Given this list of marker genes Trps1, Atp2b2 (ATPase, Ca++ transporting, plasma membrane 2), Trip12, Apol10b, Gm4894, Arid5b, Rbm12, Lrp6, Naa30, Kcnb2, Wnt5a, Rac2, Csnk2a2, Cts8, Naa12, Rora, Aard, Cnbp, Tpbg, Ift140, Abhd13, Ptpn2, Hps3, Bloc1s3, Mier1, Yes1, Naa16, Mageb3, Tmx4, Plek, Celf2, Prom2, Map4, Mtrr, Dtwd2, Tbl1xr1, Myt1l, Tbx3, Shisal2b, Cd55 (NCBI Gene Id 13136), Dusp6, Mllt1, Mex3a, Cox15, Snx12, Vwc2l, Grk3, Copb1, Plcb3, Ttc12, Ssh2, Tcstv2b, Champ1, Map3k4, Mrgprb2, Mast4, Tfam (transcription factor A, mitochondrial), Snrpb, Cd200r4, Fndc3a, Foxo1, Mark2 (MAP/microtubule affinity regulating kinase 2), Zfp26, St8sia4, Ifnlr1, Eml4, Zmat1, Xiap, Speer4d (spermatogenesis associated glutamate (E)-rich protein 4D), Zfp955a, B4galt7, Cds1, Cflar, Rnf4, U2surp, Ccdc34, Synpr (NCBI Gene Id 72003), Rb1cc1, Dicer1, Prelid3b, Fam53c, Cdk7, Stxbp5, Ythdc1, Fbxl14, Cxcr4, Asah1, Sfxn3, Gab3, Unc5c, Snapc1, Adrb2 (adrenergic receptor, beta 2), Utp4, Fat1, Adra1a, Zmym5, Cnot6, Ttc6, Nop16, Ap1g1, Arid1b, Nucks1, Tmtc1, Zhx3 (zinc fingers and homeoboxes 3), Ado, Ranbp6, Map3k2, Nfya, Zfhx4, Washc4, Hccs, Impa1, Azi2, Slc8b1, Dynlt3, Etv1, Gpr158, Gm21190, Pabpc5, Speer4c1, Hook3, Samd8, Piezo2, Sirt6, Tulp4, Bicd1, Lrrc58, Metrn, Lgmn, Mindy2, Satb2, Acer3, Rsbn1l, Slc35a5, Pbx2, Selenoi (selenoprotein I), Pou2f1, Tirap, Notch1, Fthl17e, Mphosph9 (M-phase phosphoprotein 9), Poldip3, Kras, Tmem170, Mboat7, Zbtb41, Lrrc38, Camk2a, Ythdf3, Tmem263, Paip1, Gm10377, Znrf2, Mia3 (NCBI Gene Id 98575), Ptprf, Entpd4, Larp4 (NCBI Gene Id 52147), Zfp345, Nlgn2, Zbtb44, Cdk17, Ppih, Aplp2, Zfp280c, Bend6, Neurod6, Csnk1a1, Cpeb4, Hsp90aa1, Fam3c, Mrpl35, Pafah1b1, Htr1a, Jade1, Tnrc6b, Uri1, Cbfb, Sall1, Dcaf17, Ssx2ip, Zbtb21, Edem3, Septin8, Ppp4r3b, Nrxn3, Tet1, Ipcef1, Casp3, Armc2, Kcnh5, Pak3, Col19a1, Tm9sf3, Nbeal1, Fam227a, Tfap4, Fzd6, Entpd7, Akap6, Gse1, Sgk1, Tbx18, Homer2, Prkd3, Sgcz, Dcun1d3, Ccdc93, Tube1, Dstyk, Hyal4, Tmppe, Ddx3x (DEAD box helicase 3, X-linked), Prrg4, Cep170, Stxbp6 (NCBI Gene Id 97823), Hipk1, Dpp8, Sntb2, Arl8a, Erich5, Fbxw7, Reep1, Ppp6c, Eif2s3x, Aff2, Boc, Tcstv2c, Pou3f2, Sgcb, Syt14, Frmd4a, Syt6, Gja8, Cdh2, Rnf170, Zbtb37 (zinc finger and BTB domain containing 37), Ift80, Prickle2, Hsf5, Stk10, Fbxo28, Dmrt1, Rab18, Hepacam2, Tgif1, Scn8a, Eif2b1, Rmnd5a, Espnl, Fgf9 (fibroblast growth factor 9), N4bp2l2, Fgf10, Naaladl2, Marveld1, Dars1, Gria3, Elavl1, Bcl6b, Ldlrad3, Maoa, Tyms, G2e3, Matn1, Ntng1, Gpm6a, Asb8, Ppfibp1, Vezf1, D1Pas1, Mgat2 (mannoside acetylglucosaminyltransferase 2), Lonrf3, Fcgr4, Rhobtb1, Foxp2, Terf1, Scd4, Luzp2, Rab23, Cd44, Iws1, Nap1l1, Trim6, Klhl15, Gfra2, Hmgb2, Ralbp1, Creb1 (cAMP responsive element binding protein 1), Arrdc3, Vps13d, Twf1, Ptpra, Rnf44, Ptk7, Arl13b, Uqcc4, Tcstv2a, Gpr22, Smc6, Zfp518a (zinc finger protein 518A), Fstl1, Tbc1d30, Fgfr1, Zbtb34, Adra2b, Asb7, Gm20815, Gsk3b, Agl, Osbpl6, Vsig10l, Med18, Sox5 (SRY (sex determining region Y)-box 5), Plaur, Cutal, Tenm2, Ercc6, Ranbp3l, Slc10a2, Cdc42ep4, Nr6a1, Wasl, Esrrg, Lrrtm3, Zfp799, Fthl17a, Hoxd11, Pou4f1, Samd4, Ran, Pex13, Chml, Mdga2, Kdm1a, Rai2, Gngt1, Anapc1, Megf10, Phf14, Dnajc6, Exoc5, Cpeb2, Tcstv3, Osbpl8, Ctnna3, Crebzf, Tmem88b, Ct55, Nufip2, Slc15a1, Ints12, Rbpj, Hycc2, Tceanc, Psme3, Nab2, Snurf, Rest, Syt15, Cyria, Itsn1, S1pr3, Kmt2a, Zfp462, Fut11, Oprm1, Rplp0, Satb1, Ckap4, Trim21, Pde8b, Bend4, Slc22a23, Sgms2, Celf1, Dmp1, 1700001F09Rik, Mvb12b, Fsd1l, Zfx (zinc finger protein X-linked), Fubp1, Tanc2, Maml3, Senp5 (SUMO/sentrin specific peptidase 5), Zfp512, Mllt11, Rpusd2, Rflnb, Cacna1d, Scai, Rictor, Mef2c, Cxcl12, Il1rap, Rbm20, Fbxo3, Prickle1, Gm8267, Kdm5a (NCBI Gene Id 94042), Ecm2, Paqr6, Cln8, Bloc1s2, Glis3, Mbnl2, Thsd7a, Usf3, Pou3f1, Hapln1, Tcstv4, Elmod2, Slc10a4-ps, Scn3a, Zfp113, Nhlh2, Cadps2, Dock6, Acsf2, Tdrd3, Ankrd13c, Wwtr1, Tent5a, Far1 (NCBI Gene Id 72904), Dtx3l, Trim33, Sycp3, Shisa9, Bri3bp, Nmt2, Il17re, Phf8, Slc16a1, Tcstv7a, Irf1, Poglut3, Nat14, Six4, Ddhd1, Lclat1, Ctnnd1, Dag1, Nfib, Zfp292, Zfp719, Tgfbr3, Gabrb2, Esyt2, Tmed9, Slc10a4, Canx, Bcl2l12, Ppp1r27, Tmem87b, Hykk, Spryd7, Ccdc92 (NCBI Gene Id 52823, coiled-coil domain containing 92), Adam17, Onecut3, Galc, E4f1, Hs3st5, Bdnf, Mbtd1, Ssr3, Dgkb, Msantd3, Slf2, Epb41l2, Gm5127, Zfand4, Slc7a2, Nectin3, Sash1, Pef1, P2ry4, Scn7a (sodium channel, voltage-gated, type VII, alpha), Bclaf1, Itgav, Tsc22d3, Scfd1, Zmat3, Lrba, Fkbp5 (NCBI Gene Id 52022), Depdc1b, Scg2, Lnpep, Neu3, Mtcl2, Ifnar2, Khdrbs2, Hmgcll1, Ep300, Rpgrip1l, Tcf7, Cebpg, Ctsc, Kalrn, Srgap1, Ppm1k, Gtf2a1, Ddhd2, Prtg, Usp32, Aebp2, Hbegf, Zfp654, Elovl7, Unc13c, R3hdm2, Gtf3c3, Zfp422, Prkaa2, Tcf4, Sppl2a, Sema3c, Pde4c, Fosl2 (fos-like antigen 2), Apbb2, Dusp1, Faf1, Tnpo1, Atrn, Synpo2, Hoxd9, Gpr107, Nras, Pcdhb16, Trim35, Arl5a, Mtf2, Dennd6a, Tsen34, Tcerg1, Ccdc126, Vamp4, Atp6v1a, Pten (NCBI Gene Id 70161), Igf1, Akap5, Phlpp1, Gna13, Ptpn21, Gm5796, Ttll7 (tubulin tyrosine ligase-like family, member 7), Alg6, Plch1, Zfp84, Ereg, Gpat3, Ranbp1, Kcnk3, Runx1t1, Bcat1, Semp2l1 (SUMO/sentrin specific peptidase 2-like 1), Tcp10c, Elp2, Arih1 (NCBI Gene Id 23806), Dusp10, Gbx2, Kif1c (NCBI Gene Id 237826), Adamts5, Lrrtm4, Szrd1, Lhx2, Nfe2l1, Ccnd2, Clcn5, Prkx, Plekhm3, Pcyox1l, Ap3m1, Bcl11a, Pkp4, Zfhx3, Shisa2, 4921517D22Rik, Actr6, Tgfb2 (NCBI Gene Id 98738), Dach1, Timd2, Thumpd1, Septin11, Ppp1cb, Wdr25, Cbln4, Gna14, Gdpgp1, Lrrn4cl, Enah, Sgpp1, Clock, Kdm4a, Cpeb3, Psg16, Myocd, Ube4a, Irf2bp2, Pcdhb22, Il19, Vkorc1l1, Kif5c, Tfdp1, Abca8a, Cxxc4, Fut9, Dap3, Rab6b, Nup107, Ehf, Arhgap19, Otud7b, Trio, Sec63, Dgke, Get1, Myo1b, Mllt3, Paqr9, Pcdh18, Prdm1, Cnnm3 (cyclin M3), Marf1, Kpna2, Elavl4, Zfp329, Cdc14a, Smc5, Lsm6, Apod, Cbx5, Zc3hav1l, Cyp26b1, Itpripl2, Ooep, Ptf1a, Cdh1 (NCBI Gene Id 12550), Extl1, Mylk4, Herpud2, Skint7, Pank3, Mapk8, P2ry1, Myod1, Vav2, Zfand1, E130308A19Rik, Setx, Prb1b, St3gal4, Braf, Psd3, Ctso, Preb (NCBI Gene Id 97258), Tmed10, Thbs2, Eif5a2, Pcdhb19, Gm10375, Sh3bgrl2 (SH3 domain binding glutamic acid-rich protein like 2, NCBI Gene Id 68100), Yipf6, Smim13, Kbtbd7, Cep15, Cdc37, Prpf18, Trim30a, Slc25a51, Grm5, Parpbp, Ebf2, Cops7b, Arfgef1, Socs4, Crebrf, Ywhab (NCBI Gene Id 80438), Trmt9b, Fbxo43, Afap1, Kctd12, Zrsr2, Plaa, Prr7, Parp11, Ubtd2, Zfp92, Ugcg, Riok3 (RIO kinase 3), Pdcd10, Rarb, Elf2, Macf1, Nfat5, Atl2, Ythdc2, Hnf4g, Rere, Ddx39b, Gm5148, Supt16, Fign, Deptor, Cdh20, Arl5b, Med12, Calml3 (NCBI Gene Id 70405), Cdk6, Luc7l, Tcstv5a, Slc35f1, Dennd2c, Cstf3, Fli1, Sgce, Tspan31, Sin3b, Htr4, Pbrm1, Sdr16c5, Shroom2, Nip7, Noc2l, Faxc, Serpinb10, Gpr12, Runx3, Orai2 (NCBI Gene Id 677007), Tasor, Pcdh9, Fpgt, D16Ertd472e, Ctnnd2 (catenin delta 2), Zfp106, Gmip, Bnip5 (NCBI Gene Id 78191), Rrp1b, Igfbp5, Bdp1, Glipr2, Traf3ip1, Pogk, Arb2a, Cyp2u1, Ccnjl, Hspa5, Slc25a46, Jun (jun proto-oncogene), Actc1 (NCBI Gene Id 11464), Arhgap28, Upf1, Wdtc1, Cand1, Dnmt3a, Zbtb7a, Polr3b, Snx11, Tmub2, Zdhhc21, Mafb, Ddx46, Rimbp2, Rabgap1, Trim32, Mapk10, Syn2, Speer4e1, Fbn2, Cmtm6, Atxn7, Zbtb26, Cacna1c, Rorb, Gm21083, Semp2l2a, Jarid2, Sec22b, Onecut2, Nuak2, Med1, Septin7, Dyrk1a, Tardbp, Ccbe1, Msi2, Mapk6, Grb2, Unc45b, Ino80d, Abraxas1, Ldlr, Mrfap1, Phtf2, Zmym2, Ddx19b, Zfp503, Kmt5b, Fam187a, Bcl11b, Hspbap1, Pttg1, Tnrc6a, Reep3, Hoxa10, Camk2g, Gpr183, Chd9, here is a description of the gene set: from publication Chen Y, Wang X (PMID 31504780) studied in species Mus musculus Genes predicted to be targets of miRBase v22 microRNA mmu_miR_1192 in miRDB v6.0 with MirTarget v4 prediction scores > 80 (high confidence targets). Mouse Gene Set: MIR_1192